Given this list of marker genes SNAP25, STXBP1, PPFIA2, RAB3A, STX1A, SYT1 (synaptotagmin 1), LIN7A, SYN2, PPFIA3 (PTPRF interacting protein alpha 3), APBA1, TSPOAP1, PPFIA4, LIN7C, UNC13B, RIMS1 (NCBI Gene Id 22999), SLC18A2, SYN3, PPFIA1, CPLX1, LIN7B, VAMP2, SYN1, CASK, here is a description of the gene set: Dopamine Neurotransmitter Release Cycle species: Homo sapiens Human Gene Set: REACTOME_DOPAMINE_NEUROTRANSMITTER_RELEASE_CYCLE